Given this list of marker genes Mccc2, Acaca, Slc5a6, Pccb, Pdzd11, Hlcs, Pcx, Btd, Acacb, Mccc1, Pcca, here is a description of the gene set: studied in species Mus musculus Mouse Gene Set: REACTOME_BIOTIN_TRANSPORT_AND_METABOLISM Biotin transport and metabolism